Given this list of marker genes MTERF3, PARP6, DLAT, MEGF10, PIPOX, PTPRF, GPAT4, NAGPA, CTXN2-AS1, TMEM14EP, COA4, PDZD2, ZSCAN5A-AS1, TIMM10, SLC4A1AP, SETD5, SET, TNS2, COPB2-DT (NCBI Gene Id 100507291), WDFY2, MTCO3P12, PPP1R15B, LINC02044, TSLP, COBLL1, CPT1C, CEP170, ZNF608, WARS1, ETV5, RND1, CD320, LINC02136, S100A10, KIAA0408, SPRY1, ENSG00000227733, MORC3 (MORC family CW-type zinc finger 3), JSRP1, RRM1, ENPP3, RN7SL346P, TRIM41, MIR615, IDH1-AS1, GGTA1, PLXDC1, C12orf75, BANP, LBR, ATG10, MT-RNR1, LINC02453, WDPCP, ITGA1, NBR1, SLCO4A1, FAM200A, ATP8A2, STX16-NPEPL1 (STX16-NPEPL1 readthrough (NMD candidate)), PGM2L1, GLIPR1L1, ANKRD13C-DT, PAIP1, TYSND1, NOL7, SLC43A1, RNVU1-30, CDKN2B-AS1, PARN, CCNG2, MAP4K1, LINC01227, ASB3, ANKS1B, CAMK4, LMO4, TFPT, HIBCH, AMACR, SECISBP2L, MIR575, PRKAG1, EMX2, ENO2, NRSN2, PPFIBP1, KIAA1549, MIB1, SLC24A1, CRABP2, GLCE, MXI1, NBEAL1, GTPBP2, TPI1P2, MAP3K6, CADPS2, C1orf21-DT, MTF2, DLC1, RABGGTA, ALDH1A2, TMEM143 (NCBI Gene Id 55260), KDM6B, LRRC49, GNG5, DCAF8, PPIC, TRIM59, ADAM11, NOP10, EMC3-AS1, CACNB3, FBXO36, FZD4, CROCCP2, KRT19P2, CNPPD1, IPO11, PRDM5, TNFSF9, NBEA, MOSPD3, ENSG00000259704, CPNE8, ERLEC1, ENSG00000233577, PCAT19, BASP1 (NCBI Gene Id 10409), LINC00938, H2BC18, RNF217, USP44, HERC1 (HECT and RLD domain containing E3 ubiquitin protein ligase family member 1), MAML1, MRPL51, SRI, REXO5, AKNA, MRPS28, GINS1, LMNB1, C3orf38, MAZ, LUC7L2, SEMA3A, PNKP, RAG1, TGIF1, CHCHD2, H2AC21, UCHL5, PRR11, RIMKLB, EPS15-AS1, TBC1D31, CD37, LINC02210-CRHR1, ZNF792, SEC22B, CDC42SE1, STUM, MIR4453HG, PIGC, SNRNP35, OGFOD2, NUBPL, PARD6B, GNAI1, SMIM27, CHIT1, COX14 (NCBI Gene Id 84987), CUL4A, RUFY1, ICAM4, SLC1A5, MARCHF5, EFEMP2, EPHA3, ACOT11, F2RL1, TCF4, RERE, SULF1, ERCC4, TPM3, RPL22L1, DNM1L, MRNIP, ANKRD34A, PRDM4, ZNF398, INO80D-AS1, FOXO4, CCT3, TRD-AS1, HSPD1, ACOT9, PITPNB, PLPP1, TMBIM6, CENPF, TPP2, DNAJC25, PTGFRN, CDK5RAP2, COPS5, COX5B, JAG1, ALCAM, SYNM, RRP1, ARHGAP31-AS1, BSDC1, TSC22D4, NBPF1, ORMDL2, CD46P1, ARHGEF28, SREK1, MTERF4, TLN1, IER3-AS1 (NCBI Gene Id 105379695), PPP2R1A, SMAD7, NUP42, CHD3, SMIM14, ENSG00000233030, DPH6, TOMM40, SMARCA4 (SWI/SNF related, matrix associated, actin dependent regulator of chromatin, subfamily a, member 4), TBC1D23, TSACC, SCAT2, KDM7A, RHOBTB3, SUPV3L1, AKAP9, SH2B1, BRWD1, ASCC1, MRPS2, SRPK2, KRBA2, SLU7, SMIM8, SEPTIN7, ITFG2-AS1, MIR3936HG (MIR3936 host gene), HMBS, SGO1-AS1, PPP4R3B, SORD, OAZ1, KPNA1, KCNB1, LIAS, GABBR1, ITGB3BP, PARP2, PEAK1, NXN, FNTB, TMEM242, SLC1A2, PURB, IQCG, KLRG1, PRRT2 (NCBI Gene Id 81865), DUSP6, TMEM199, CARHSP1 (NCBI Gene Id 23589), CELF6, CNOT2, CSNK1D, LINC02366, RRP9, RAB17-DT, MPHOSPH6-DT, CLPB, NUAK1 (NCBI Gene Id 9891), SELENOWP1, DDR2, RBSN, IRX4, CHMP4B, HAPSTR1, BRIX1, NETO2, ZMPSTE24, ARHGEF2-AS2, SRPK1, RNVU1-23, GNPNAT1, CR1L, RMDN3, BATF2, ZBTB14, LINC02506, GRHL3-AS1, RICTOR, ATP6V0B, COQ8B (NCBI Gene Id 79934), ALKBH5, FAM131A, TPR, HBP1, SDCCAG8, RPS13, SMG7-AS1, AMOTL1, AFG3L2, MAPK4, CHCHD3, CIPC, MTCL3, RPL14, MRNIP-DT, AFG2B, PLCXD1, PRKAA1, PSMA3, HLA-B, TBC1D20, GZF1, GPRC5D-AS1, CCND3, ZNF687, PLEC, HNRNPUL1, ZNF19, CCDC159, TRAF6, CMAHP, MTO1, ENSG00000257184, BEST1, ALG2, LRIG3, RANBP3-DT, CD68, CDCA7, ARB2A, PDXK, TRIM28, MIR194-1, USPL1, KIFAP3, ISCA1 (NCBI Gene Id 92236), ZKSCAN8, CBFB, TRMT1, HUS1, SHLD3, DLG3-AS1, AHCYL1, AIG1, TMEM65, BLOC1S4, RNU7-27P (NCBI Gene Id 100147814, RNA, U7 small nuclear 27 pseudogene), HASPIN, SELENOS (NCBI Gene Id 55829), PLD1, ADPGK-AS1, HOXD3, SGSM1, HMGB1, BPHL, PIGO, PARD3-DT, NDFIP2, CFAP119, CHST12, CPSF2, USP38, CECR2, CXXC4, NT5C3A, TIAL1, PCBP2, B9D1, DDX54, DCP1A, PDZD8, VPS4B, HNRNPLL, PHB1P18, RFX1, NPC1, APRT, CAPN1-AS1, KIF2A, DNAJC10, CAMK2D, GPR161, RINT1 (RAD50 interactor 1), CYB561D2 (cytochrome b561 family member D2), KCNJ5, SMG1, SLFN11, RPUSD4, DDX59, CCNB2, TBX3, PGAP1, C1orf105, SUMF2, TRIB1, TMEM217, CCT2, UNC45A, PAXIP1-DT, PTX3, ARFGAP2, LINC02210, IRF2BP1, FLT3, EOMES, CENPBD2P, HDDC2, TRAPPC13, BCORL1, SUB1, YEATS4, RABEP1, C11orf98P3, HNRNPA0, MT-TF, FBXL19, TRAF4, NUP43, FBXO27, GJA1, ZNF687-AS1, SNAP47, UHMK1, ERC1, MRPL39, KHDRBS1, SMIM14-DT, GALT, ACAP3, DYRK2, UGGT1, RPL23A, TIPRL, POLR3G, ZNF839, GEMIN2, VPS29, GCHFR, CSTB, RPL39, H4C8, VRK2, PRMT5-AS1, RASA2, TRAF5, TRDMT1, CORO1C, ACLY, NUDT3, RAI1, RPS27A (NCBI Gene Id 6233), QSOX1, PPIL3, PITX1, RPS26P29, LETMD1, ZNRD2, ABCB10, DEDD2, SEMA6D, HDAC5, LIG1, MIB2, ZNF343, PROSER1, TBPL1, ACP3, TSHZ3, RN7SL2, POLH, HS3ST3A1, UST, SNORD2, DDX3X, MN1, NPLOC4, GPC6, C6orf226, ENC1, KRIT1, ZNF207, LYPLA2, CYP2J2, ETV3, ACVR1B, GATA6, ANAPC4, WASF1, FGGY, PIGO-AS1, SMG1-DT, KLF7, SALL1, PLCD3, KRAS, HCFC1R1, NFE2L1, SUPT3H, FAAH2, DPH6-DT, CAV2, RNF217-AS1, DAB2, ZNF583, TENM3, KIF11, MEMO1, UBA1 (NCBI Gene Id 8247), MTHFD2L, BIRC3, SFPQ, DBI, PPP6R3, FEZ1, BRD4, FAM185A, GTPBP3, RPS12, CYB5R3, SBNO1-AS1 (NCBI Gene Id 112268105), DPCD, ZNF181, ARHGEF37, MECOM, EPCIP-AS1, DST, TIMM22, PPP1R1A, FMC1-LUC7L2, RP9, MCC, SNAPC5, RUSC1, EDARADD, LINC01515, RASA1, FMC1, ZNF526, TNC, GTF2A2, DPP8, POLR2I, RAD9B, TBCC, RAD9A, FTCDNL1, FMNL1, DDX42, LIN28B, APH1A, TRIM25, HECTD2, MAN2A2, VEPH1 (ventricular zone expressed PH domain containing 1), RNU7-29P, MIR4799, CAV1, DYNLT5, TUBA1B, CDK7, C15orf61, DNA2, FBXL3, NR2F1, RALA (RAS like proto-oncogene A), EMC7, FRMD3, NRXN3, GNAL, ZFC3H1, RPS29, TLE3, PNRC2, H4C16, RUFY3, TBCD, SNX15, ZDHHC17, GPI, BCAR1, RNU7-41P, RSU1, RGS5, UBE2H, TRIM37, UBE2Q2P1, TRIM47, FAM151B-DT (NCBI Gene Id 121232370), PRMT3, SNORA14B, PLEKHM3, LINC01535, CARD10, PDRG1, MIR4505 (microRNA 4505), PKP2, FZD1, PIGH, C9, TMEM219, ATP5MF-PTCD1, HCG14, PTPN13, FOSL2, PDE4DIP, SUZ12P1, SCP2, ZBTB44, ZNF503-AS2, KHSRP, NOP2, ARID2, SEPTIN7-DT, DLX6, LINC00365, PKD2L2, FOXG1, PELO, LINC02814, ALDOA, SFR1, RAPGEF3, VGLL4 (vestigial like family member 4), IGFL4, RN7SL525P, RAD23A, HNRNPH3, ZNF775 (NCBI Gene Id 285971), ACVR1, ACTR3 (NCBI Gene Id 10096), CEBPG, ZNF131, H3C9P, MSANTD3, TBK1, TRIM2, INTS13, SQSTM1, METTL15, VILL, ABHD3, INKA2, CCDC178 (coiled-coil domain containing 178), CRBN, RPL27A, RAB3GAP2, IRX3, MBD1, BBX, OTULIN-DT, RANBP3 (RAN binding protein 3), CABIN1, SF3A3, PCGF1, HOXA11-AS, TRIM23, PABPC1L, TMEM51, TEX30, RIOK2, ABCA4, TENT2, CEP152, SARNP, PPM1D (protein phosphatase, Mg2+/Mn2+ dependent 1D), STAP2, COX6A1, ADAR, BTG3-AS1, GCNT2, TMEM68, IFRD1, LMNB1-DT, ELL2, LINC03014, MMACHC, KAT6B, AGO3, DLGAP5, SRP54-AS1, CCNC (NCBI Gene Id 892), ERBB3, GLT8D1 (glycosyltransferase 8 domain containing 1), EMC4, TMEM167B, NKX3-1, PRICKLE2-AS3, CBLL1-AS1, USP38-DT, GUSBP2, ANO6, PPP1R9B, PCSK2, LINC01990, USP8, SLC25A12, COL19A1, ZEB2, ARSK (NCBI Gene Id 153642), CELF1, XPOT, ABT1, CLHC1, NIF3L1, PAXBP1, TTC1, ATAD1, MKNK1, GHDC, TTC21A, CSPP1, EXOSC6, ZNF248, PLAUR, TSPAN12, SAMD4B, NAGLU, PITPNC1, RPS6KA1, CLIP1, TMA16, DHPS, UBXN1 (UBX domain protein 1), GDF15, DRC3, JMJD1C, SNHG7, ATP23, EXOSC1, HSPE1, ECHDC1 (NCBI Gene Id 55862), SAV1, ZNF561-AS1, CHEK1, HSP90B1, GRHL3, VIRMA, TRERF1, B4GALT6, NCL, NDUFA12, CWC25, ODR4, TUBGCP3, TMEM202-AS1, LRP1B, EFCAB7, LINC00933, GATM, C18orf32, ARHGEF38, GMNC, ERBIN-DT, HOXD11, CEP57L1, LPXN, CREM, NCOA2, SCAPER, BICRAL, RBPJ, H1-5, GBA1, POP4, ERBIN, NDUFA4 (NCBI Gene Id 4697), MFHAS1, PTCD1, RAB11A, LCDR, GPSM3, GRK4 (NCBI Gene Id 2868), MT-CO1, ESRRB, ZBTB22, ADGRA3, LRRC37A5P, FAM81A, BMS1, DACT3-AS1, HMG20A, ROR1-AS1, ARID4B, LARS2, FRMD4B, TPBG, CLN6, HDAC7, ENSG00000239142, HIPK3, ZBTB45, RNU6-194P, TAF1B, COTL1, PCID2, CCDC62, TSHZ2, MAP1A, CZIB, SKIC3, RAB33A, ENSG00000237101, GMEB1, CARHSP1-DT, M6PR, EME1, DLG4, NRL, DACH1, SIVA1, ZBTB8A, PAXIP1, DDA1, NSA2, GART, TTC28-AS1, DNAJC28, LINC00652, TMEM198, NBPF3, JADE1, RNF138, ANXA2, CFL1P1, PRPF18 (pre-mRNA processing factor 18, NCBI Gene Id 8559), THOC6, C4orf54, IFTAP, C17orf75, TUBA1C, MRPL54, MIR548AL, AP2A1, XPO5, MINDY1, CREB5, CDC40, CSNK1G1, LYSETP1, NFIX, PTPRS, FES, TTBK2, CAVIN2-AS1, TRAPPC3, CD46, CBY1, RGL1, DZIP1L, UBE2M, VASP, EXOC6B, ST7, HEXIM1, RITA1, MACIR, MAP7D1, ZNF589, PBX1, DNAJB4 (NCBI Gene Id 11080), STIM2-AS1, CFLAR, TRIP12, CEP85, CAPN1, SESN1, RSPO2, RPS3, TRIM59-IFT80, SLC22A5, PDXDC2P, ATF6, SCFD1, CNOT4, AQP6, MPND, KPNB1-DT, KLF2-DT, NOL6, RAB11FIP2, SPSB3, DIAPH3-AS2 (NCBI Gene Id 100874196), FGFR1OP2 (NCBI Gene Id 378428), BMI1, SMURF2P1, LINC02901, CHTF18, STK10 (serine/threonine kinase 10), DIPK2A, NPRL2, ENSG00000273162, NIPA2, SERTAD3, CACTIN (cactin, spliceosome C complex subunit), SH3RF2, HMCN1, MIF4GD, ZFP91-CNTF, MIR129-2, NIP7, COG8, SERTAD1, FOXP4-AS1, TMCO6, ARHGAP24, PTDSS1, CLMP, TYW3, ZNF561, SLC16A1-AS1, GSTO1, FKBP9, RASGRF2-AS1, LTBP1, PSMA7, MFSD6, NFATC2, ZNF12, WASHC4, ZNF233 (zinc finger protein 233), NRP2, STAT6, SLC39A3, SPRY2, LARP6, LINC00240, UROS, EPDR1, ISYNA1, MILIP, CTTNBP2, COPZ1, GGPS1, H2AX, RBM23, SYNGR4, HIGD2B, ORC1, ADNP, GALK2, POLK, RBM39, NDUFS6, MT-TW, ELOVL1, GLT8D2, TNNT1, ATL2, LCORL, LLGL1, DSCAML1, JAK2, SNHG10, ARRB2, RPL9, SNORD42B, CCDC107, PKM, LY6G6D, MACROH2A2, TMBIM4, C9orf85 (NCBI Gene Id 138241), STRN3 (NCBI Gene Id 29971), NR2F1-AS1, OMA1, NR2C1, SPCS3, CNIH3 (NCBI Gene Id 149111), ADRB1, FZD4-DT, THAP9-AS1, DNMT1, ACAD11, CEP131, MDM2, HOXB3, C6orf58, ZNF281, ANKRD13C, KCNAB1, SLC2A11, COL4A5, TYRO3, PRKAG2, EIF4A1, ZNF143, INTS14, PSIP1, RAB17, SMG9, PFKM, BACH2, PCDH7, SERTAD2 (SERTA domain containing 2), PGAM1P5, MXD4, TMEM242-DT, NUBP2 (NCBI Gene Id 10101), TRIM11, NPAS3, EIF4G2, NUBPL-DT, STX12, LY6G6E, CDNF, TTLL5, HNRNPD-DT, DRAIC, TNS2-AS1, P3H2, GPX1, RBM45, CIP2A, HAPLN2, SUZ12, CCDC47, PSME3 (NCBI Gene Id 10197), MCRIP2, SYNPO, CTDSPL2, SEPSECS, PDCD6IP, PTPRG, RAB18 (RAB18, member RAS oncogene family), IPO5, CDC7, SATB2, CFDP1, CNRIP1, CNTNAP2, CNOT3, PPP1R13L, TIAM1, MIF4GD-DT, RING1, CMBL (carboxymethylenebutenolidase homolog), ADCY6, FDXR, CCNI, GARNL3 (GTPase activating Rap/RanGAP domain like 3), POLR1G, RRN3P1, MRTFA-AS1, ADD3-AS1, RNF43, WIPF2, AKIRIN2, HLA-C, ZNF221, PFKFB2, TET3, FAM133B (family with sequence similarity 133 member B), ANKRD40, MDGA1 (MAM domain containing glycosylphosphatidylinositol anchor 1), MED12L, PAAF1 (NCBI Gene Id 80227), PGGT1B, UBE3A, ARHGAP5, PSMG4, DNAJC6, NSD3, NAA38, ZNF436, GAS1RR, IQCH-AS1, VCAN, HYI, PLAC8, PIK3C2B, MED11, DPYSL2, ELMOD3, DDX55, SLC25A45, RPS16, ZKSCAN2, CNOT1, DAGLB (NCBI Gene Id 221955), RPL37, ATP10B, MOXD1, CTXN2, FAM98A, OCEL1, ITIH4, CCNB1, ANO8, SPPL2B, HOXB-AS3, EFNA3, FOXP2, MYO7B, ANAPC5, RABGAP1L, EPS8, PLK3, SNORD15A, TRIP10, ADGRB3-DT, SLC6A9, TMEM101, RAB29, CERCAM, MT-TQ, DCLRE1B, POLD1 (NCBI Gene Id 5424), PITX2, DDX10 (DEAD-box helicase 10), MRPS33, EYA4, ZFP36, PHF12, SNHG30, ZNRD2-DT, CZIB-DT, LAGE3, NTS (NCBI Gene Id 96646), ERG28, HOXA-AS3, MOSMO, ETS2, MLF2, ELOVL6, UFC1, TMEM218, SLC2A13, MICA, ENSG00000277020, CBR4-DT, C1orf21, GABPB1, EMX2OS, MRPL27, SLC12A1, NFIB-AS1, RBM28, THAP10, ADPGK, CEP70, PDXDC2P-NPIPB14P, DOCK5, WEE2-AS1, ZNF780A, SGO1, UTRN, FRMD5, BBS4, PEMT, PLEKHG3, TRIP6, DOCK11, MCTP2, HLA-A, IRF2BP2, AJUBA-DT, SMG8, GABPB1-AS1, TTC33, SLC25A26, CTSH, TDRD3, DKKL1, FAM184A (NCBI Gene Id 79632), PLPBP, ADPRHL1, COL17A1, YOD1, DAXX, RHOJ, CCDC12, ECHDC2, NKAIN1, NDFIP2-AS1, SH3YL1, EXOSC4, COL4A6, RAD1, CCSER1, SAFB, ZSCAN5A, TMEM237, LBX1-AS1, HEMK1, MSL2, CTDSPL2-DT, FAF1 (Fas associated factor 1), RNU1-6P, KRT8, CDPF1, PROS1, KLHL22, JOSD1, PGBD4, CCDC89, CHTOP, ZNF217, PTCH1, MYO1E, MZF1, PPP1R12B, RETSAT, HSPA14, LINC01152, HCG15, MIR219A1, TM7SF3, SEC31A, HAPLN1, SERF2, ANG, LIMA1, MIR7845, DLX6-AS1, TRPM7, ABHD17B, RALGAPA2, KIF22, ARL2BP, PHF23, DCAF11, EXOC4, FLNC-AS1, SIL1, LINC00265, RPS26, MIR4512, BUB1B, SEC61B, CXXC4-AS1, CNP, SMIM15 (small integral membrane protein 15), CLK3, DHRS3, MFN1, GATA6-AS1, ZNF790-AS1, STIM2, RNVU1-14, GMNN (geminin DNA replication inhibitor), BHLHE40, SAFB2, RRAGC-DT (RRAGC divergent transcript), MCTP1, FOXP4, NUF2, MICB, RSRP1, ACTA2, PIERCE1, SCG5, ENAH (NCBI Gene Id 55740), CCND2, FBN2 (fibrillin 2), GDNF, MAPK10, ASPH, ZFP1, HOXA3, TUBB, GPHN, CFL1P4, TGS1, FLOT1, ZNF56P, ARID5B, GRAMD1B (GRAM domain containing 1B, NCBI Gene Id 57476), CD55, CD8A, WDR11, EMC3, HK1, HEY2, CEP192-DT, CUL4B, MIR3913-1, TOM1L2, NCLN, NAGK, NEO1, ZNF143-AS1 (NCBI Gene Id 651375), GNAI3, CYP20A1, PSMD9, PRDX2, CBFA2T2, LINC03015, ENSG00000266313, TNRC6B, ENSG00000283674, METTL26, TMEM59, CDK18, URB2, WDR89, QKI, HOXA4, APC2, MTMR9, MATR3, NUAK2, COPB2, ATXN2L, FAM118B, GEMIN8, MYCBP, SMYD3, RAI14, HLA-DQA1, PALLD, WDR41, MRC2, GFM2 (GTP dependent ribosome recycling factor mitochondrial 2), ZFHX2, GIN1, SLFN5, SNCA, LINC03060, FOXQ1, TARBP2, PMPCB, PELO-AS1, PGM1, TEAD2, IMP3, ZBTB44-DT, RAD17, ADCY6-DT, TMEM132A, ADGRB3, SKIDA1, KAZALD1, BECN1, ZFYVE1, THUMPD2, PIK3R3, CDK2AP2, DENND4A, TMEM141, PABIR1, SERBP1, DDX60L, MSMP, SKAP1, KDM4B, CCDC88C, BAZ1A-AS1, POLR3B, LRRFIP1P1 (LRR binding FLII interacting protein 1 pseudogene 1), DLX4, TIMELESS, XRCC2, CCDC163, RASGRP4, TK1, CBR4, AK4, C8orf34, PKIG, CACYBP, RNF40, PUF60, BRD2, KCNC3, NKIRAS1, USP48, PTMA, HNRNPD, PRKCI, ANXA4, ARIH1, RNF130, GFOD2, PUSL1, SLC35F1 (NCBI Gene Id 222553), USP32, FEM1A, STRAP, DYNC1I1, PLCL2 (NCBI Gene Id 23228), CCNE1, PKD2L2-DT, TCEANC2, CAP2, HSP90AA1, SCUBE2, CNNM1, DZIP3, B4GALT2, HELZ, STAG2-AS1, U2AF2, RLIG1, ARF3, REV1, PRKCE, ZNF580, ATF7IP2, RNU6-92P, MAML3, TENM3-AS1, PCSK5, RFX2, LINC02532, DHDDS (dehydrodolichyl diphosphate synthase subunit), TGFBI, CERT1, ZKSCAN5, ARMC8, SRRM2, SETDB1 (NCBI Gene Id 9869), BEND6, PHF21B, STAG2, SLC30A10, ITPRIP, FGD4, PTPA, CCDC15, GNAQ, FRAS1, ZMYM4, AGGF1, OSBPL7, MPC2, MIR1915 (microRNA 1915), PLEKHA8P1, UBA5, FAM227A, RTN4, ABCB9, ERI2, PTPRK (protein tyrosine phosphatase receptor type K), WWTR1, ZNF573, ALKBH3, TTI2, NUTM1, PARD3, MRM2, RABGAP1, ZDHHC16, PLA2G12A, ATP6V0E1, ANKRD12, TLCD1, MRPL37, SIX4, RNU5A-1, P3H2-AS1 (P3H2 antisense RNA 1), ENTREP3, LINC03028, TFAP2E-AS1 (NCBI Gene Id 105378645), SFMBT1, KHDC4, HYI-AS1, TCTA, ANXA2P2, CRTAP, NUP155, NCOA7, ARL4A, DEPDC5, FZR1, PPIP5K2, KIF21A, TMEM248, SESN2, ZMPSTE24-DT, MEX3B, LINC00663, CDKN2A, ISL2, THAP2, NRP1, KPNB1, HOXB4, GNG11 (NCBI Gene Id 2791), TNPO3, SMG7, NSD1, RN7SK, GLRX5, USP11, COPS3, MVP-DT, BACE1, CRADD, TP53BP1, P3H3, TFAP2A, CHD1, TOMM20, MGAT5, DAAM1, MTCL2, POC5, NFKBID, NEK8, MDH1, UBE4A, MTND5P11, NDRG2, RBBP7, ABI1, ATG5, HOXC5, ZFP91, HLA-DMA, LINC01778, ENSG00000237813 (novel transcript), RPPH1, MTR, LSM7, SAR1B (NCBI Gene Id 56680), CLIC1, PRPF31 (NCBI Gene Id 6106), OTULIN, UBE2H-DT, RPS7, REXO4, ARRDC4, UBTF, PMS2, FBXW7, ITPR2, SSBP1 (single stranded DNA binding protein 1), AJUBA, CDC42BPA, SHC4, ENSG00000265246, ENSG00000246308, MAPK8IP3, ATRNL1, ZNRF2, ALG1, SPCS1, RDX, MIF, ASXL2, NCK1, CSRP2, KCTD3, LPCAT4, EIF5A, SENP1, HDGFL2, LTBP4, PIF1, CBX4, DNAJB12, GSTA4 (NCBI Gene Id 2941), EBF2 (EBF transcription factor 2), NRCAM, C5orf24 (chromosome 5 open reading frame 24), SRSF1 (serine and arginine rich splicing factor 1), MYO3A, MIDEAS, YKT6, EIF4A2, IDH1, CASC2, C6orf132, DDX20, MGAT1, CRHR1, GINS3, WDR25, MAN2C1, MARCHF4, TLE2, SCAND3, ITGA6, MCCC1, GMPR, OLFML2B, LNCATV, ULBP1, ZNF341-AS1, PLS3, PRPF40B, LYSMD3, PDE4D, AAK1, EPHA5-AS1 (NCBI Gene Id 100144602), DNAJC25-GNG10, CSNK1A1, AIMP2, EIF3J-DT, CEP120, MST1P2, ISG20, TRABD2B, YWHAZ, PANK1, MIR1915HG, FBXO9, C17orf58, PIN4, RN7SL521P, STEAP2, DIMT1, MED23, TMEM39B, ATP6V1F, TTC21B (NCBI Gene Id 79809), PPA2, EML2, STEAP2-AS1, CHD9, TLK2, FEM1C, TAF5L, TWF1, PLSCR1, ARHGAP10, HSD17B1-AS1 (HSD17B1 antisense RNA 1), ODAD4, NUDT1, STAM-DT, B9D2, SON, HLA-L, RUNX1, CHPF, EYA1, TMEM127, ARID1A, CGGBP1, DOCK9-DT, LRP6, PARP3, NR4A1, COL24A1, ZNF829, LDHB, C2orf76, SNHG5, DRG2, USP54, TMEM116, ARPC5, FRS3, APBA3, RO60, ZNF384, IRX4-AS1, ATP5MF, BCCIP, ZNF568, PVR, FAM3C, POLDIP2, ENSG00000232995 (novel transcript), TMEM100, MANSC1, GNG2, WDR11-DT, MYCBP2-AS1, GLI3, VPS33A, NRIP3-DT, ZNF521, DNAH2, GPBP1, RAB34, RNU11, ELP6, UFL1-AS1, PRC1, MBOAT1, FREM2, JMJD4, ZNF473CR, FHIP1A (FHF complex subunit HOOK interacting protein 1A), ANKIB1, TLCD3B, STX16, RHOA, HSPE1-MOB4, ELP3, HOXA-AS2, EIF3K, RPL35A, FAM220A, BASP1-AS1, COQ3, SUPT7L, MCM3, TCF7L2, TBCB, LDHA, AGFG2, TSPAN10, ST7L, TTC41P, WWC1 (NCBI Gene Id 23286), CBLL1, RNF14, STAM, IPP, STOX2, NCAPD2, RAP1GAP, CSNK1G2, RETREG2, AQR, MPHOSPH6, PTP4A2, FSCN2, VIM, RNASE4, H2AC12, VLDLR-AS1, USP21, NAA50, NDUFA10 (NADH:ubiquinone oxidoreductase subunit A10), CCBE1, MSL1, DEPDC1B (DEP domain containing 1B), ZNF165, SRP54 (NCBI Gene Id 6729, signal recognition particle 54), LINC00958, YAP1, RDUR, LNPEP, TMEM181, CCDC112, TSHR, KCNK1, SMAP2 (NCBI Gene Id 64744), FAM135A, NCK1-DT, NPRL3, MARS1, ZFHX4, HPSE, UBE2L3, LEKR1, SCAF11, CCDC33, ACP1, ZNF581 (zinc finger protein 581), JPT1, FSIP2, MTHFD2, here is a description of the gene set: Human Gene Set: MZF1_TARGET_GENES Genes containing one or more binding sites for (MZF1) in their promoter regions (TSS -1000,+100 bp) as identified by GTRD version 20.06 ChIP-seq harmonization. from publication Yevshin I, Sharipov R, Kolmykov S, Kondrakhin Y, Kolpakov F (PMID 30445619) studied in species Homo sapiens